Given this list of marker genes Ube2d1, Sppl2a, Fadd, Tnfaip3 (NCBI Gene Id 21929), Tnf, Tradd, Cyld, Clip3, Casp8, Sppl2b, Traf1, Ulk1, Tnfrsf1a, Usp4, Rack1, Mib2, Optn, Rps27a, Ubb, Usp21 (NCBI Gene Id 30941), Spata2, Birc3, Otud1 (OTU domain containing 1), Ikbkb, here is a description of the gene set: Reactome Pathway: Regulation of TNFR1 signaling electronically inferred by orthology from the curated human pathway part of: TNF signaling species: Mus musculus This event has been computationally inferred from an event that has been demonstrated in another species.<p>The inference is based on the homology mapping from PANTHER. Briefly, reactions for which all involved PhysicalEntities (in input, output and catalyst) have a mapped orthologue/paralogue (for complexes at least 75% of components must have a mapping) are inferred to the other species.